Given this list of marker genes EXT1, ENG, SERPINF2, COL3A1, EIF2AK4, EXT2, here is a description of the gene set: studied in species Homo sapiens The presence of blood in the pleural space. Human Gene Set: HP_HEMOTHORAX Hemothorax